Given this list of marker genes NFATC3, ITK, ZNF683, CD83, IL9, BRD7, KLF6, IL18, PTPN2 (NCBI Gene Id 5771), UCP2, STAT6, HLA-B, LIPA, MIR486-1, ARID1A, FASN, B2M, CD79B, BCL11B, SMARCD2 (NCBI Gene Id 6603), LY9, KLHL25, CMTM7, PIK3R2 (NCBI Gene Id 5296), IL4, SOCS5, CARD11, PIR, RSAD2, TSPAN2, ITPRIPL1 (ITPRIP like 1), APCS (NCBI Gene Id 325), TRPM2, HMGB3, ACTB, TNFSF9, LGALS1, TMEM176A, TREM2, PRDX2, CBFB (core-binding factor subunit beta), LILRB4 (NCBI Gene Id 11006, leukocyte immunoglobulin like receptor B4), SMARCC2, NAGLU, LCK, FZD8, SOX12, IL1B, CR1, TUSC2, ZC3H12A (NCBI Gene Id 80149), CD1D, MR1, HLA-DRA, DOCK2, ZFP36L2, CD79A, APP, CD3D, IRF1, THEMIS, LGALS3, KAT5, PPP3CB, PLCL2, GATA3, PTPRC, SEMA4A, SIRT1, PRKCA (NCBI Gene Id 5578), CDH17, ATP7A, SMAD7 (SMAD family member 7), HLA-DRB1, RIPK3, CSF2, IL10, MALT1, HDAC4, IL6ST, MYH9, SFRP1, EIF2AK1, PBRM1, EGR3, CCR7, ACTL6A, RPL22, BLNK, LY6D, ARID2, ARID1B, IGHM, ICOS, SLC46A2, GPS2, MYC, MIR21, ZAP70, FOSL2, RC3H1, CD19, RIPK1, MT1G, SMARCA4, VAV1, CEBPE, AQP8, FES, NKX2-3 (NCBI Gene Id 53631), LRRC8A, AZI2 (5-azacytidine induced 2), RELB, IL1RL2 (interleukin 1 receptor like 2), FBXO7, LEF1, ICOSLG, CD28, SMARCE1, BAD, RUNX3, TYRO3, BAK1, SLAMF8, DNAJA3, CD2, MERTK (NCBI Gene Id 10461), ENTPD7, BRAF, BMI1, CTSL, DLL1, MIR223, STK11, VCAM1, DLL4, NTRK1, ADGRG3, RORC, CLEC4E, ZEB1, SLC39A7, TMEM176B, PIK3R6, CASP8, CAMK4, GPR183, BAX, CHD7, FZD7, MIR17HG, FCER1G, CYLD, PTK2B, ITGA4, TAOK3, DROSHA, TNFSF4, CYP26B1, HCLS1, ITFG2 (NCBI Gene Id 55846, integrin alpha FG-GAP repeat containing 2), PGLYRP1, SH3RF1, PCK1, IFNA2, GPR18, PRKCZ, C1QC, CD4, ZBTB16 (NCBI Gene Id 8070), CD86, GAB3, DCLRE1C, BRD4, XBP1, BMP4, MYB, SOCS1, GPR89B, BCL3, PRELID1, RBPJ, RUNX2, HLA-G, IL1A, ASCL2, MED1, KMT2A, RNF41, DOCK11, AICDA, PBX1, SLC25A5, STAT5A, METTL3, PREX1, FOXO3, TGFB1, RUNX1, IL33, LARGE1, SPN, MIR125B1, BTK, IRF2BP2, LMBR1L, IFI16, KDELR1, NFAM1 (NFAT activating protein with ITAM motif 1), RIPK2, TBK1, ITGB1, ZBTB7A, FZD9, IRF8, GATA2, NOTCH2, LOXL3, GATA1, TGFBR2, IL12RB1, PKNOX1, TPD52, ATM, PGLYRP3, LIF, ADAM8, SLAMF1, IRF4 (interferon regulatory factor 4), JAK1, FOXP3, TNFSF13B, PTGER4, PIK3R1, TMEM131L, VPS13A, MAFB, PHF14, PLCG2, SP3, CLEC4G, FGL2, MSH2, VNN1, PSMB11, JAG2, POU2AF1, NR3C1, CDK6, IL15RA, HDAC5, DHRS2, ITM2A, ADAM10, ITGB8, MFSD8, LEP, ITPKB, AP3D1, LGALS9, BCL6, CLCF1, NDP, IFNG, CLEC12A, EZH2, IL12B, GPR68, FANCD2, ATG5, HSF1 (NCBI Gene Id 642255), IL21, PRTN3, ZBTB46, STAT4, TCF7, SLC4A2, DIAPH3, RASGRP1, PRDM1, JUN, STAT3, IHH, MMP14, AIRE, CEBPG, PNP, CCR9, FNIP1, CD8A (CD8 subunit alpha, NCBI Gene Id 925), BTN2A2, ST3GAL1, THOC5, CCR2, PRKDC, HHEX, RAG1, SMARCB1, GBA1, FUT7, FLT3, NRROS, DTX1, KIT, DDRGK1, SPIB, CEBPA, LEPR, JAK3, USP44, TP53, WNT4, MTOR, RABL3, CSF1R, FANCA, NFKBIZ, NRARP, ATF2, CFLAR, ZFPM1, LILRB1 (NCBI Gene Id 23445), GAS6, SOS2, IRF7, DCAF1, ITGB6, PDE2A, CCL19 (NCBI Gene Id 6363), BATF3, FLT3LG, NCKAP1L, IL31RA, TNFRSF9, INHA, IFNL1, PATZ1, CR2, JMJD6, SOD1, IL4I1, CTNNBIP1, CD74, LTBR, ID2, ADIPOQ, CD40LG, IL6R, DCSTAMP, NHEJ1, TOP2B, NFKBID, JUNB, RORA, IL23A, IL2, AMBRA1, PSG9, ERBB2, PTPN6, IFNB1 (interferon beta 1), TESPA1, SYVN1, LFNG, L3MBTL3, TCF3, MMP9, TCIRG1, SOX13, BCL2 (NCBI Gene Id 596), IL34, YY1, LAPTM5, HOXA7, NCAPH2, CD80, INHBA, RHOA, NPM1, FCRL3, TLR4, HDAC9, AGER, ZFP36L1, SHH, BATF2, GLI2, IL36B, GPR89A, PTCRA, PPARG, MDK, IGHE, DUSP10, CLPTM1, PLA2G2D, SMARCD3, POLM, SMARCD1, TRAF6, CDKN2A, CTLA4, ANXA1, TSC1, SOS1, TNFSF18, SLAMF6, IKZF3, CD46, ADAM17, F2RL1, KCNK18, MFNG (MFNG O-fucosylpeptide 3-beta-N-acetylglucosaminyltransferase), ACIN1, KAT2A, FCGR2B, ARMC5, WNT10B, MIR30B, MEN1, IL7, SRF, CD27, STAT5B, AXL (NCBI Gene Id 558), CALCA, PRR7, MS4A1, HLA-DOA, RB1, CRTAM, IL2RA, CEBPB, LYL1, LILRB2, CD69, GLI3, KAT7, FADD, DNAJB9 (DnaJ heat shock protein family (Hsp40) member B9), WNT1, TLR2, PSEN1, PAX5, PPP2R3C, VPS54, EP300, SOCS3, ZBTB1, FOXN1, SYK, ABL1, C17orf99, INPP5D, CSF1, SART1 (NCBI Gene Id 9092), RAG2, RC3H2, PF4, NKAP, VSIR, IL6, TRAF3IP2, PTPRJ, AP3B1, PCID2, TLR9, MYD88, PHF10, IKZF1, FOXP1, SPINK5 (serine peptidase inhibitor Kazal type 5), XRCC6 (NCBI Gene Id 94359), RHOH, LGALS8, ZC3H8, IL18R1, CD3G, PDP2, LYN, PIK3R3, SPI1, CCDC39, OPA1, CCR6, HMGB1, FZD5 (NCBI Gene Id 81561), PIK3CD, KLRC1, NDFIP1, TBX21, ONECUT1, IL23R, PARP1 (poly(ADP-ribose) polymerase 1), ZBTB7B, SHB, SMARCA2, PTPN22, CLEC4D, PGLYRP2, IL1RL1, FOXJ1, DOCK10, GPR65, CD3E, EOMES, ZMIZ1, CDC42, NFIL3, NLRP3, MIR145, SASH3, BATF, SOX4, ADA, TRIB1, LAG3, TNFSF8, IL7R (interleukin 7 receptor), ACTL6B, UBD, CTNNB1, IL2RG (NCBI Gene Id 3561), VEGFA, LIG4, SMARCC1, PDE1B, TMEM98, RARA, CRACR2A, HLX, TOX, BRD2 (NCBI Gene Id 9803), IL15, EGR1, FOS, ARID3C, IL11, IL4R, QKI, IL27, here is a description of the gene set: The process in which a relatively unspecialized cell acquires the specialized features of a mononuclear cell. studied in species Homo sapiens Human Gene Set: GOBP_MONONUCLEAR_CELL_DIFFERENTIATION